Given this list of marker genes GMPPA, AKT2, KCNJ11, TRAPPC11, HNF1A, SLC16A1, TBX19, GCK, SLC25A36, PROP1, MC2R, PCSK1, ABCC8, SLC37A4, TANGO2, UCP2, AAAS, TXNRD2, NNT, HADH, POMC, INSR, POGZ, MRAP, GLUD1, STAR, here is a description of the gene set: studied in species Homo sapiens Hypoglycemic seizures Human Gene Set: HP_HYPOGLYCEMIC_SEIZURES